The following is a description of a gene set: Any apoptotic process in a neutrophil, any of the immature or mature forms of a granular leukocyte that in its mature form has a nucleus with three to five lobes connected by slender threads of chromatin, and cytoplasm containing fine inconspicuous granules and stainable by neutral dyes. Mouse Gene Set: GOBP_NEUTROPHIL_APOPTOTIC_PROCESS species: Mus musculus, and this is the list of marker genes: Fcgr2b, Itgam, Il18, Slc7a11, Hcar2, Anxa1, Itpkb, Cxcr2, Pik3cb, Ifng, Pik3cd, Il6, Cd44